Given this list of marker genes Pacrg, Pdha1, Scml2, Dctn6, Etv1, Phactr1, Nbeal1, C1d, Prkca, Csmd2, Inpp5a, Prkaa1, Cbx3, Xpr1, Cstf3, Polr2g, Mbnl1, Crppa, Ube3a, Pop5, Zc3h6, Ids, Hcn4, Mdh1, 5730455P16Rik, Cacnb2, Naa30 (NCBI Gene Id 75009), Mpg, Mab21l1, Map3k7cl, Pou4f1, Hapstr1, Zfp709, Runx2, Hcn1, Pzp, Prrx1, Zfp882, Tmc3, Ell2, Psmd7, Scai (suppressor of cancer cell invasion), Atf2, Muc15, Slc8a1, Kcnip1, Mospd2, Fmo5, Zfp626, Calb1, Zfp871, Actbl2, Sestd1, Dtd1, Xpo7, Cp, Nufip2, Trpm3, Gabra4, Lep, Rilp, Spopl, Myo5b, Cadps, Myrip, here is a description of the gene set: Mouse Gene Set: MIR_6942_3P Genes predicted to be targets of miRBase v22 microRNA mmu_miR_6942_3p in miRDB v6.0 with MirTarget v4 prediction scores > 80 (high confidence targets). from publication Chen Y, Wang X (PMID 31504780) studied in species Mus musculus